Given this list of marker genes Camkk2, Calm1, Camkk1, Calm2, Calm3, here is a description of the gene set: CaMK IV-mediated phosphorylation of CREB studied in species Mus musculus Mouse Gene Set: REACTOME_CAMK_IV_MEDIATED_PHOSPHORYLATION_OF_CREB